The following is a description of a gene set: Genes up-regulated in comparison of untreated CD4 memory T cells from young donors versus those treated with TSST at 40 h. studied in species Homo sapiens With increasing age, the ability of the immune system to protect against recurring infections or to control chronic infections erodes. The objective of the current study was to identify gene expression signatures in elderly CD4 T cell responses from publication Yu M, Li G, Lee WW, Yuan M, Cui D, Weyand CM, Goronzy JJ (PMID 22434910) Human Gene Set: GSE36476_CTRL_VS_TSST_ACT_40H_MEMORY_CD4_TCELL_YOUNG_UP, and this is the list of marker genes: USP34, BTRC, DSC1, TRMT2B, DNAJB9, PIK3IP1, SGK1, SEMA4C, INPP5A, CD69, RALGAPA1, TMX4, TOB1, RPL35A, RNASET2, PITPNC1, FCGBP, CRY2, CYTH1, MOAP1, CNOT2 (CCR4-NOT transcription complex subunit 2), TCTA, PTGER4, TXK, KLF7, TSC22D3, ARHGEF18, ARL4C, KCNK15-AS1, ZNF331, GOLGA7, ANXA1, PDCD4-AS1, PBX3-DT, PFN2, CRTC3, PXN, PIK3R1, FAM13A, CIRBP, SIK1, UQCRB, PER1, SETD2, SORL1, KLF2, FOSB, GOLGA4, NLRP3, TUG1, CYTH4, PIK3CA, RALGPS1, GZMK, SPINK2, DPEP2, RASGRP2, BTG1, ADD3, PTPN4, TOX, RNF44, MARCHF8, LYPD3 (LY6/PLAUR domain containing 3), CAPRIN2, EVI2B, PBXIP1, MTMR10, DUSP1, EEF1D, KLHL20, KIAA0513, LEF1, IL11RA, RORA (NCBI Gene Id 6095), CDR2, CAPN3, PLAC8, MED6, TSPYL4, NUP160, INPP5D, KLRB1, NBPF10, TNFRSF10B, RLF, TRIB2, ATMIN, LEPROTL1, SMURF1, LLGL2, DSTYK, HIC2, NOX4, DNAJB1, TPT1, CLK1, SUN2, SMIM10L1, SIK3, TTC17, FRAT1, ZNF131, MXI1, CHD1, UBL3, FOS, GSE1, TXNIP (thioredoxin interacting protein), HECA, RAP1GAP2, TENT5C, KAT6B, IRS2, ZFP36L2, NR3C2, JADE1, TRAPPC10, RFPL3, EPHA4, ATP2B1, TMEM123, TNFAIP3, SMAGP, PCMTD2, TENT5A, RRN3P1, TNIK, ENTPD4, RIPOR2, KLRG1, ZMYM5, DAZAP2, ZNF136, SARAF, IL10RA (interleukin 10 receptor subunit alpha), PADI2, PTP4A1, ATP2B2, CDC42SE1, PELI1, RAD52, SERINC5, CCNL1, GPR183, SIGIRR, PCF11, SLC16A2, MX2, MAPRE2, KIF21B, ZNF14, ARID5B, FAM53B, YPEL5, CERNA1, ARL4A, TMEM41B, TMEM127, CD177, CFH, MGAT4A, PPP1CB, CASP8, ATG12, EZH1, AQP3, HDAC4, TIPARP, HSD17B11, FAM8A1, RPS27 (ribosomal protein S27), NDEL1, AMT, PLCL2, ZNF639, KANSL2, CXCR4, RAB11FIP2, CD48, FGF9 (fibroblast growth factor 9), DYRK2, DYRK1A, LAPTM5, RPL34, USP3, TSPYL1, MYLIP, NEFL, ITGB2, CTSF, KLF11 (NCBI Gene Id 8462), GABPB1-IT1, RGCC, LPCAT3, JUN, ATG14, RBM48